Given this list of marker genes Nsdhl, Osbpl2, Hsd17b7, Sqle, Cyp17a1 (cytochrome P450, family 17, subfamily a, polypeptide 1), Ube2i, Fdx1, Slco1b2, Stard6, Lbr, Hsd3b4, Hsd17b2 (hydroxysteroid (17-beta) dehydrogenase 2), Mvk, Cyp11b1, Lhb, Hsd3b3, Dhcr7, Gc, Akr1b7, Stard3nl, Akr1d1 (NCBI Gene Id 208665), Osbpl1a, Srebf1 (sterol regulatory element binding transcription factor 1), Cyp7b1, Slc51a, Cyp27a1, Scap, Cyp7a1, Akr1c6 (NCBI Gene Id 83702), Osbp, Srebf2, Tspo, Cyp27b1, Hsd11b2, Slco1a4 (solute carrier organic anion transporter family, member 1a4), Ncoa1, Slc27a5, Sc5d, Nr1h4, Fdxr (ferredoxin reductase), Osbpl6, Srd5a2, Akr1c21, Hsd3b1, Fdft1, Cyp2r1, Hmgcr, Idi2l, Akr1c20, Cyp11b2, Cyp46a1, Srd5a3, Fabp6, Acat2, Akr1b10, Pomc, Amacr, Pias4, Srd5a1, Hsd17b12, Slc10a2, Hmgcs1, Fdps, Hsd3b9, Mbtps1, Cyp19a1, Stard5, Akr1b1, Mbtps2 (membrane-bound transcription factor peptidase, site 2), Stard4, Idi2, Tspoap1, Hsd17b11, Cyp51, Scp2, Ran, Serpina6, Ncoa2, Ch25h, Osbpl9, Akr1b8, Hsd17b14, Cyp11a1, Acot8, Abcc3, Hsd17b1, Hsd17b3, Alb, Cyp24a1, Baat, Hsd11b1, Mvd, Kpnb1, Hsd3b2, Pmvk, Fdx2, Hsd3b6, Tm7sf2, Hsd3b7, Dhcr24, Cyp21a1, Hsd3b8, Plpp6, Stard3, Cga, Idi1, Ebp, Lss, Hsd3b5, Osbpl3, Slc51b, Cyp39a1, Sts, Osbpl7, Rxra, Hsd17b4, Msmo1, Sumo2, Slc27a2, Slc10a1, Vdr, Cyp8b1, Abcb11, Arv1, Acox2, Ggps1, Star, here is a description of the gene set: species: Mus musculus Metabolism of steroids Mouse Gene Set: REACTOME_METABOLISM_OF_STEROIDS